The following is a description of a gene set: Genes up-regulated in kidney biopsies from patients with acute transplant rejection compared to the biopsies from patients with well functioning kidneys more than 1-year post transplant. studied in species Homo sapiens Human Gene Set: FLECHNER_BIOPSY_KIDNEY_TRANSPLANT_REJECTED_VS_OK_UP A major challenge for kidney transplantation is balancing the need for immunosuppression to prevent rejection, while minimizing drug-induced toxicities. We used DNA microarrays (HG-U95Av2 GeneChips, Affymetrix) to determine gene expression profiles for kidney biopsies and peripheral blood lymphocytes (PBLs) in transplant patients including normal donor kidneys, well-functioning transplants without rejection, kidneys undergoing acute rejection, and transplants with renal dysfunction without rejection. We developed a data analysis schema based on expression signal determination, class comparison and prediction, hierarchical clustering, statistical power analysis and real-time quantitative PCR validation. We identified distinct gene expression signatures for both biopsies and PBLs that correlated significantly with each of the different classes of transplant patients. This is the most complete report to date using commercial arrays to identify unique expression signatures in transplant biopsies distinguishing acute rejection, acute dysfunction without rejection and well-functioning transplants with no rejection history. We demonstrate for the first time the successful application of high density DNA chip analysis of PBL as a diagnostic tool for transplantation. The significance of these results, if validated in a multicenter prospective trial, would be the establishment of a metric based on gene expression signatures for monitoring the immune status and immunosuppression of transplanted patients. from publication Flechner SM, Kurian SM, Head SR, Sharp SM, Whisenant TC, Zhang J, Chismar JD, Horvath S, Mondala T, Gilmartin T, Cook DJ, Kay SA, Walker JR, Salomon DR (PMID 15307835), and this is the list of marker genes: CD52, HLA-F (NCBI Gene Id 3134), LCP1, APOC1, LAPTM5, STAT1, LGALS9, WARS1, PTPRC, CSTA, SLA, LTF, TYMP, GBP2, GLIPR1, ISG20, ARPC1B, S100A8, IL10RA, UBC, FCGR3A, RGS10, CD163, CFD, COL6A3, IL4R, CD2, CD3D, PDE6D, IFI30, AOAH, IFITM1, CD27, INPP5D (NCBI Gene Id 653796), CXCR4, CCL5, RAC2, FCER1G, GZMA, POLR2A, DOCK2, ALDOC, LILRB4 (NCBI Gene Id 11006), CORO1A, FABP5, LCK, CCND3, GLUL, USP9X, IL10RB, TMEM131L, S100A4, LCN2, MOXD1, IFFO1, PRKCB, PIM2, ENTPD1, SFN, FCN1 (ficolin 1), ITGB2, TRBC1, CD53, RASSF2, C1QB, VSIG4, CELF2, LST1, AIF1, ADAM15, CD8A, CD14, FCGR1A, PSMB8, HCLS1, LY86, RAB31, RAB27A, RHOH, MMP9, EIF2AK2, ACKR1, RBMS1, TYROBP, CD48, GMFG, TNFRSF1B, UBE2L6